The following is a description of a gene set: species: Homo sapiens Human Gene Set: MIR4284 from publication Chen Y, Wang X (PMID 31504780) Genes predicted to be targets of miRBase v22 microRNA hsa-miR-4284 in miRDB v6.0 with MirTarget v4 prediction scores > 80 (high confidence targets)., and this is the list of marker genes: CCDC32, DCTN5, ZNF554, RALA, RALGAPA1, CLCN3, ANKRD62, PSMB2, GLIPR1, SEMA6C, PCBD2, ELL, KPNA4, ZNRF3, SYN2, UGCG, CA5B, CHRNB2, ZMYM3, NLK, DENND10, NAV2, MICAL2, APBA1, ERC2, SRL, SCML4, NFAT5, AP4E1, INSIG1, TXNRD3, UGDH, FBXL18 (F-box and leucine rich repeat protein 18), CORO2B, ZCCHC14, FZD4, TSC22D2, SWT1, ENC1, AAMP, MIA3, ELP5, RAB18, PABIR2, INHBA, FZD2, HNF1B (HNF1 homeobox B, NCBI Gene Id 6928), CREBL2, BCL2L11, ADAMTS6, AGR2, HDAC1, PMS1, TGIF2, SNX27, BTAF1, TP53, RLIM, ZNF443, GARIN1A, C8orf58, ALG2, MIX23, CDK17, SEPTIN12, LMTK2 (NCBI Gene Id 22853), RSBN1L, RNF41, TSC1, PLA2R1, KRTAP17-1, CALCR, PEX26, GATA5, MAGI1, REPS2, GAD1, ZFR2, ZNF799, XPO1, ADCY5, TENT5A, GGA2, IL6R, RNF138, STC2, VPS53, NPL, CYTH2, SOS1, ZNF445, UBFD1, MATN3, ADSS1, KCTD21, PLEKHH2, MEX3A, FTO, DMC1, TRPC4AP, NAP1L5, RASGEF1A, SIGLEC11, GPR4, CCDC8, PRDM1, SCML2, TTLL4 (NCBI Gene Id 9654), SLC30A7, IMPA1, CTSB, AAK1